The following is a description of a gene set: species: Homo sapiens Genes up-regulated in T reg cells: wildtype versus FOXO1 and FOXO3. from publication Ouyang W, Beckett O, Ma Q, Paik JH, DePinho RA, Li MO (PMID 20467422) Human Gene Set: GSE21678_WT_VS_FOXO1_FOXO3_KO_TREG_UP Identification of Foxos target genes in Treg cells. Foxo1and Foxo3 are transcription factors of Foxo family. CD4+Foxp3+ Treg cells isolated from wild-type and Foxo1/3-deficient mice were analyzed by global gene expression profiling. Results indicate Foxos regulate expression of a subset of Treg cell signature genes and genes in control of T cell homeostasis, signaling and metabolism., and this is the list of marker genes: CEACAM4, SNORD89, INPP5A, TECTA, ZBTB10, DNM3, CH25H, SCYL2, SLC35A2, RABGGTB, EHD4, IL2RA, MMRN1, VTI1A, ZNF750, ELOVL7, IFNGR1, ARID1B, PIGA, SLC16A6, SMAP1, GPHN, C19orf18, TXNDC11, NARF, CLUHP3, ATAD2, FAM76B, PNPLA8, PIAS2, FRMD4B, KMT2E, SREK1, RIOK3, MAMLD1, ZNF410, ERO1A, USP14, AGFG1, ARIH1, CD99P1, MITF, CT45A5, AP1G1, SLC9A8, ICOS, ABCA1, ZNF682, POLB, DNAJC25, NFKBIZ, PELI1, MED6, ZBTB21, FANCL, ZNF736, XAGE3, MASTL, SYTL3, DENND6A, USP12, ALG13, LRRC39, LRRC8C, BRMS1L, FTHL17, LPIN1, AREG, SESN3, H2BC4, SMIM3, USP16, GEM, ULBP2, MB21D2 (NCBI Gene Id 151963), SPAG9, MYO18B, MAP3K7CL, CTLA4, LMNB1, TNNT1, FSD1L (fibronectin type III and SPRY domain containing 1 like), SDCBP, MAP3K8, GPRIN3, PSMD12, ZEB1, ADIPOR1, AP3M2, GLA, SGK1, CCDC141, REL, PLPP5, KCNMB3, UVRAG, RAB5A, SLC11A2, ITGBL1, MAP3K5, NAMPT, FBXO32, CCNH, CABP7, EZH2, DNAJB9, RRAD (NCBI Gene Id 6236), MFSD14A, SDC4 (NCBI Gene Id 6385), BEX1, H2BC21, IRF2BP2, CRYBG1, MND1, FBXL22, LRRC66, PIM3, DNAJC27, CDR1, C6orf62 (chromosome 6 open reading frame 62), OSER1, KLHL15, TRPC1, CD200, GPR183, ZNF165, DLEU2, PDCL, TRBV10-2, ALG9, PCLAF, PRKAR2B, NANS, RAP2C, SEC24A, TXNDC16, ASAP1, USP47, LONRF3, ARL5B, PAFAH1B1, SRGN, INTS6, KBTBD8, FNIP1, IRF2BPL, VAV3, HIP1, SEC14L1, USP3 (ubiquitin specific peptidase 3), TENT5C, SOCS3, VDAC1, CETP, DNAJB14, CPEB4, SH3BP5, NINJ1, MED13L (NCBI Gene Id 23389), NPY4R, ACVR2A, CDK5RAP2, WDR91, JMJD1C, HBS1L, PRDM1, SFMBT2, H2AC14, SRSF7, ZDBF2, CAVIN2, CAPZA3, BTG3, SHOC2, CLDN23, FCF1, SUPV3L1, MMD, PAM, FIRRE, THBS1, CEP120, GSN, SSH2, TRPS1, IVNS1ABP, CCT6B, TAF2, RRM2 (NCBI Gene Id 6241), RPGR, TP53BP2, LINC01619, RPRD1B